The following is a description of a gene set: Genes up-regulated in NCAM1+ SELL bright versus NCAM1- SELL dim. Human Natural Killer (NK) cells comprise two main subsets, CD56bright and CD56dim cells, that differ in function, phenotype and tissue localization. To further dissect the heterogeneity of CD56dim cells, we have performed transcriptome analysis and functional ex vivo characterization of human NK cell subsets according to the expression of markers related to differentiation, migration or competence. Here, we show for the first time that the ability to respond to cytokines or to activating receptors is mutually exclusive in almost all NK cells with the exception of CD56dim CD62L+ cells. Indeed, only these cells combine the ability to produce interferon (IFN)-gamma after cytokines and proliferate in vivo during viral infection with the capacity to kill and produce cytokines upon engagement of activating receptors. Therefore, CD56dim CD62L+ cells represent a unique subset of polyfunctional NK cells. Ex vivo analysis of their function, phenotype, telomere length, frequencies during ageing as well as transfer experiments of NK cell subsets into immunodeficient mice suggest that CD56dim CD62L+ cells represent an intermediate stage of NK cell maturation, which after restimulation can accomplish multiple tasks and further develop into terminally differentiated effectors. from publication Juelke K, Killig M, Luetke-Eversloh M, Parente E, Gruen J, Morandi B, Ferlazzo G, Thiel A, Schmitt-Knosalla I, Romagnani C (PMID 20505160) Human Gene Set: GSE21774_CD62L_POS_CD56_BRIGHT_VS_CD62L_NEG_CD56_DIM_NK_CELL_UP studied in species Homo sapiens, and this is the list of marker genes: DCT, TNF, CCR2, IRF8, CD69, GJB5, LAPTM4B, LY86, PLAC8, ARL4C, DEUP1, GRIN2A, SIPA1L2, INMT, C3, TREM1, EGLN3, PIK3AP1, CALCB, ITLN1, VIT, TIMP1, TRAM2, ABHD12, EGFR, CD86, PRAF2, BBS7, ARHGDIB, NPAS3, MTUS1, UMPS, PRSS16, GRIA3, ASTL, ZIC1, TP53TG5, NRP1, KMO, VSIR, CEBPA, SPTAN1, C1orf141, ADGRG6, CDK5R1, CTNND2, SLC49A4, S1PR3, RAB3C, PAK4, SIGLEC10, TCF4, CCN2, IGSF6, DCDC2B, MOCOS, TYROBP, SLC8B1, ADGRA2, GALNT3, DGLUCY, SRGAP1, ATP8B4, PALD1, IGHM, CNN3, ALDOC, TMEM82, FFAR4, NSMCE1, NCF1, ABLIM1, CSF1R, STING1, SH2B2, MARCKSL1 (MARCKS like 1), PRTN3, NCKIPSD, FGFR4, POU3F3, TMEM79, TNFSF13B, B3GNT5, DRAM1, S100A11, ANXA2, ZNF575, LRTM2, BACE1, F13A1, SHISA2, ENC1, PI16, APOBR, DIRAS2, PTGER2, FKBP1A, SMG8, ARID5B, DNTT, MRC1 (NCBI Gene Id 4360), ARHGEF37, ELANE (elastase, neutrophil expressed), MYOCD, HOXB2, DUSP9, CA12, SGSM1, MS4A7, SPI1, ATP10A, NCF4, PHGDH, DMKN, GPC1, NFIL3, CXCR4, RASSF4, KDELR2, SATB1, TMT1B, CD52, OLFM1, CD28, ATP6V0A4, ABCD1, ZNF385B, GPNMB, DAB2, CTSG, TIGAR, GPR18, FBXW4, FAM167B, CD14, RAPH1, SELL, STARD5, PYCR1, BTLA, HPSE, APLNR, HCK, PGAM1, BCAR3, SORL1, CXCR3, SLCO4A1, POU2F2, B3GALNT1, SLC44A3, ANXA3, C16orf92, SNX18, ENTPD7 (NCBI Gene Id 57089), WDR91 (WD repeat domain 91), TIGD5, TRPS1, RASA4, THEMIS2, CPLX4, RIBC1, SYNE4, ALPL, CNGA2, SLC43A2, BAIAP2L1 (BAR/IMD domain containing adaptor protein 2 like 1, NCBI Gene Id 55971), GPR160, HES7, TLR7, TM6SF1, KIAA0930, CYBB, B4GALNT1, ATRNL1, SH2D5, PLD4, P2RY6, G6PD (NCBI Gene Id 83159), KCNQ3, TNFAIP8L2, TNFAIP8L1, GPATCH3, CDH5, LUZP1, EMILIN3 (elastin microfibril interfacer 3), CD163, GLIS3, TMEM268, MGP, PLCH2, MGST2, COL22A1, KIFC3, SELPLG, ODAD3, LCN2, KCNT2 (potassium sodium-activated channel subfamily T member 2), TUBB6, IDH1